Given this list of marker genes BMP7, COL2A1, SHOX2, NOG, BMP4, HOXD11, OSR2, HOXA11, HOXC11, OSR1, CTNNB1, HYAL1, here is a description of the gene set: species: Homo sapiens Human Gene Set: GOBP_EMBRYONIC_SKELETAL_JOINT_MORPHOGENESIS The process in which the anatomical structures of skeletal joints are generated and organized during the embryonic phase. A skeletal joint is the connecting structure between the bones of the skeleton.